Given this list of marker genes PLCH2, MICALL1, ITGA3, ATRNL1, CCDC3, SRCIN1, C3orf52, TAFAZZIN, DUSP15, RANBP10, RTN4, TFAP2E, TSPAN9, STX5, MAST3, MAP3K4, FIRRE, C5orf34, MRTFB, TFAP2A, MEF2D, CDCP1, ZNF512B, SNAPC4, UCN2, ANP32A, FAM83H, ZNF799, ZFC3H1, STRN4, CASTOR1, COL7A1, RPL28, PERP, PKP1, MTM1, FGFR3, ARRDC2, RGS12, SVIL, HMG20A, H1-2, ZBTB44, AJUBA, NDRG2, SLC12A6, CD109, ANO9, PRRC2B, ITGAX, CAMKK1, ZNF692, TTC3, DFFA, NXN, SPTAN1, ITPR2, GOLGA4, RAPGEFL1, LUC7L, TP63, DSP, TRAPPC12 (NCBI Gene Id 51112), UPF1, MYO1E, BAIAP2L1, TANC1, DAG1, AOPEP, UBE2V1, ZBTB7C, CBX7, BCL11A, NCS1, EFNA1, FGFR2, SMAD7, DUOX1, PCYOX1, WNT4, SERTAD4, HDGF, PLXNA3, SH3D19, SH3RF1, GPR19, SLC25A27, RCAN3, SPPL3, SFT2D2, SLC44A2, TLE2, HMGXB3, KRT5, NPEPPS (aminopeptidase puromycin sensitive), ABCC1, AGO1, TCTA, ARHGEF18, LDLRAD3, HDAC6, ERBB3, GRHL2, DGKZ, NEAT1, ARID1B, C9, UQCRC1, MFGE8, PRKAG1 (NCBI Gene Id 5571), FAT1 (NCBI Gene Id 2195), TFAP2B, SLC6A8, TP53BP2, SRRT, EMP2, RALBP1, PHAF1, ARGLU1, NR2C2, RAB40C, ANKRD16, INSYN2A, DUSP11, ELL3, ETS2, CHD8, FAM193B, KMT2A, NOTCH3, PTPRF, ARHGEF4, CNNM3, ANO1, PTPN14, RBM5, CAPNS2, MMP9, MAFG, HMGB3, CDH1, RHBG, IVNS1ABP, CYP2D6 (NCBI Gene Id 1569), RPAP1, ANXA8, CYC1, SERBP1, AGO4, LAD1, NFAT5, SMARCD2, RIN1, ADGRL2, TMEM216, TMCO6, PRLR, PABPC1, KMT2D, CDC42BPG, SUN2, REEP4, FAM83F, CELSR2, RPS9, STAP2, MDM4, ESRP1, PNKD, VAMP1, TNS4, DDR1, IL17RE, MBD6, GRB7, FHIP2B, TNK1, ANAPC5, CKMT1B, MKRN1, KLF5, SPINK2, PTPRU, SPINT2, MIF, SDC1, PLEKHG2, METTL17, CHDH, CRIP2 (NCBI Gene Id 8112), IL17RB, FREM2, TIAM1, TMEM63A (NCBI Gene Id 9725), HUWE1, TNK2, S100A16, FZD6, FAM168B, here is a description of the gene set: Genes down-regulated in HMC-1 (mast leukemia) cells: Cl-IB-MECA versus incubated with the peptide ALL1 followed by stimulation with T cell membranes. from publication Baram D, Dekel O, Mekori YA, Sagi-Eisenberg R (PMID 20190146) We demonstrate that the G protein Gi3 is the cellular target of the adenosine A3 receptor (A3R). By using a cell permeable peptide comprising the C-terminal end of Gαi3 fused to an importation sequence (ALL1) as a selective inhibitor of Gi3 signaling, we show that by coupling to Gi3, the A3R stimulates multiple signaling pathways in human mast cells, leading to upregulation of cytokines, chemokines and growth factors.Following contact with activated T cell membranes, endogenous adenosine binds to and activates the A3R, resulting in Gi3-mediated signaling. Specifically, the majority of ERK1/2 signaling initiated by contact with activated T cell membranes, is mediated by Gi3, giving rise to ALL1-inhibitable cellular responses. These results unveil the physiological GPCR that couples to Gi3 and establish the important role played by this G-protein in inflammatory conditions that involve adenosine-activated mast cells. We used microarrays to detail the effect of ALL1 on gene expression of HMC-1 cells activated directly by the A3 receptor, or by contact with activated T cell membranes. Human Gene Set: GSE19888_ADENOSINE_A3R_ACT_VS_TCELL_MEMBRANES_ACT_AND_A3R_INH_PRETREAT_IN_MAST_CELL_DN studied in species Homo sapiens